The following is a description of a gene set: species: Homo sapiens Three innate (B1-B, NKT, CD8aaT cells) and adaptive (B2-B, CD4T, CD8abT cells) cell-types were sorted by FACS. Three biological replicates for NKT, CD4T, CD8aaT, CD8abT cells and two biological replicates for B1 and B2 cells were generated and the expression profiles were determined using Affymetrix Mu74Av2 chip. Comparisons between the sample groups allow the identification of genes differentially expressed between the innate and adaptive cell-types. from publication Yamagata T, Benoist C, Mathis D (PMID 16623764) Genes up-regulated in NKT cell versus CD8A CD8B T cells. Human Gene Set: GSE3039_NKT_CELL_VS_ALPHABETA_CD8_TCELL_UP, and this is the list of marker genes: GPR84, SLC19A1, NUCKS1, PPP2R1A, MICALL2, MALSU1, ZDHHC16, LRMDA, MAP4, HSPB1, FOSB (FosB proto-oncogene, AP-1 transcription factor subunit), MND1, PEBP1, CEP152, RDX, SNRPF, CACNA1D, CXCL11, EEF1AKMT1, ELK3, SLC6A8, MRPL21, ITGA5, IMMT, KAT2A, ATP5MC3, CCHCR1, S100A10, DDB1, CCDC90B, SSR3, GLOD4, ALKBH7, HIBADH, NCAPD2, SRPRA, EIF3G, LLGL1, ZNF330, RNF128, GTF2E2, PDE7B, CKAP2L, SLC35B1, HYPK, DOK2, FDFT1, TMLHE, RPS19BP1, MRPL42, PRIM2, CHST1, SMYD2, ESR1, PSME1, POLA2, CCNL1, RANBP1, POFUT2 (NCBI Gene Id 23275), FEZ2, TRAPPC3 (trafficking protein particle complex subunit 3), AGFG1, NES, RPS8, GTF3C6 (general transcription factor IIIC subunit 6), MRPL40, NAMPT, TFEC, GTF2F2, ETF1 (NCBI Gene Id 9190), TIMP2, VPS53, TMEM214, TPST1, LRRC58 (NCBI Gene Id 116064), DDX50, SPCS1, SAR1B, C1QA, MB21D2, APOC2, NFE2L2, CEP170B, RAB9A, FDPS, SHB, NEK2, U2AF1, MLF2, STMN1, NHSL3, PLAUR, PSMA1, C1QB, DNAL1, RPS27L, ESYT2, TMED1, WDR43, PCLAF, FNDC4, LRRC42, HSD17B10 (hydroxysteroid 17-beta dehydrogenase 10), ALG9, WDR35, RNASE4, LCORL, CCT3, ATG5, TNFRSF9, CENPW, SSX2IP, RRBP1, WDR74, MRPS26, FARSB, PHF20, CBR1, CPLANE1, DSTN, ACVR2A, TTK, PGLS, SWI5, SCIN, HAUS1, PYCARD, CSDE1, MCTS1, PRKAR1A, PFDN6, UCHL5, BCCIP, LRATD2, LOX, ERGIC3 (ERGIC and golgi 3), NDUFA8, WDHD1 (WD repeat and HMG-box DNA binding protein 1), APPL2, HSPA14, SLC25A1, GGT1, IL1R2, FOS, COPE, APOOL, SMARCA4, NUF2, CYP2C18 (NCBI Gene Id 1562), CRLS1 (cardiolipin synthase 1), TUBA1B, PRODH, CTPS1, KY, GLMP, CUL7 (NCBI Gene Id 9820), ARL6, MRPL18, FARP1, CRELD1, CFDP1, GADD45G, SMIM15, FADS1, HDDC2, TRIM32 (NCBI Gene Id 3971), SQSTM1, GART, ELP4, MSH6, ESF1, RNF19A, CCT2, ACBD6, PTRH1, SLC7A11, IL1RN, CYP51A1, CX3CL1, SFXN1, COQ3, MAFF, NUCB2, CLEC5A, TRAPPC6A, FAIM, MTFR2, SEC24A, ANKRD28, PFDN4, TSR1, GBP4, PARVB, INTS2, P2RY12, TSC22D1, FZD5, PRDX3, CTSS, CCDC115